The following is a description of a gene set: from publication Chen Y, Wang X (PMID 31504780) Mouse Gene Set: MIR_12183_5P studied in species Mus musculus Genes predicted to be targets of miRBase v22 microRNA mmu_miR_12183_5p in miRDB v6.0 with MirTarget v4 prediction scores > 80 (high confidence targets)., and this is the list of marker genes: Nck2, Rbbp5, Bcor, Nkx6-3, Slc23a1, Cdc73, Sgms2, Ralgapb, Satb2 (special AT-rich sequence binding protein 2), Fam124a, Sgtb, Themis, Tfec, Pou2f1, Kcna1, Jakmip2, Amd2, Sec61b, Car8, Pigr, Dnase2a, Creb3l2, Syt16, Epha5, Lrch2, Fgf20, Phf3, Nus1, Atp2b2, Plod2, Baalc, Ccdc25, Runx3, Psen2, Naa12, Kmt2a, Lancl2, Snx3, Zfp85, Timp3, Lbh, Ceacam13, Megf11, Rbpms2, Slc4a4, Cox17, Purg, Btbd9, Prdm1, Phactr1, Sec22a, Dcc, Cfap68, Bpifa6, Ganab, Zfp811, Megf9, Ppp2cb, Pcdh17, Vcan, Tex16, Dlx3, Igfn1, Mrpl19, Chst11, Dbndd2, Tnfrsf23, Hnrnpa2b1, Akap11, Cplx2, Cftr, Gm6878, Ten1, Pkn2, Sec14l3, Hmgn3, Zfp60, Rab3c, Fbxo45, Eif3j2, Ttc23, Zfp935, Dram2, Pdik1l, Prx, Arhgef37, Rnf20, Cpeb3, Mef2c, Slc20a1, Kctd4 (potassium channel tetramerisation domain containing 4), Tmprss11d, Cul4b, Fxr1, Plekha8, Zfp930, Mtfmt, Adam34, Avl9, Med1, Ifi205, Magea2, AW146154, Neto1, Rbm41, Gcdh, Commd2, Emp2, Cdk14, Ifi211, Eda, P2rx7, Gcm1, Slc9a2, Fut9, Pah, Il17a (interleukin 17A), Hoxd11, Pgbd5, Erbin, Amotl1, Ranbp3l, Parp8, Il19, Ephb1, Dph5, Ccdc190, Cacna2d1, Wac, Lztfl1, Rbm47, Ercc6, 2610008E11Rik, Paqr4, Cutc, Ankle2, Chodl, Tango6, Zfp273, Thsd7a, 0610030E20Rik, Trappc3l, Slc9a9, Nol4, Tmt1a, Cct2, Strap, Tmt1a2, Mmrn2, Fasl, Rnf169, Cdh6, Zdhhc9, Krt71, Dele1, Tafa1, Nhlh2, Adamdec1, Fam168a, Axin2, Psmd1, Nrxn1, Mdga2, Brinp1, Otor, Pclo, Cngb3, Krt25, Ncam1, Tal1, Awat1, Tmem196, AI987944, Elavl4, Tyr, Jkamp, Amot (NCBI Gene Id 97610), Ppp1r9a, Add1, Plxna4, Mmp16, Akap17b, Prrg4, Cep68, Vav3, Ctla4, Sox4 (NCBI Gene Id 20677), Erg